The following is a description of a gene set: species: Homo sapiens Binding to insulin-like growth factor I. Human Gene Set: GOMF_INSULIN_LIKE_GROWTH_FACTOR_I_BINDING, and this is the list of marker genes: IGFBP6, IGFBP5, IGFBP1, INSR, IGFBP4, ITGA6, LRP2, ITGB3, ITGAV, IGF1R (NCBI Gene Id 51049), ITGB4, IGFBP2, IGFBP3